Given this list of marker genes TXNRD1, CD9, HSP90AB1, HBEGF, HSP90AA1, EEF2, here is a description of the gene set: Human Gene Set: REACTOME_UPTAKE_AND_FUNCTION_OF_DIPHTHERIA_TOXIN Uptake and function of diphtheria toxin studied in species Homo sapiens